The following is a description of a gene set: species: Homo sapiens Human Gene Set: CHENG_IMPRINTED_BY_ESTRADIOL Genes whose CpG islands became hypermethylated in breast progenitor cells pre-exposed to estradiol. from publication Cheng AS, Culhane AC, Chan MW, Venkataramu CR, Ehrich M, Nasir A, Rodriguez BA, Liu J, Yan PS, Quackenbush J, Nephew KP, Yeatman TJ, Huang TH (PMID 18339859) Estrogen imprinting is used to describe a phenomenon in which early developmental exposure to endocrine disruptors increases breast cancer risk later in adult life. We propose that long-lived, self-regenerating stem and progenitor cells are more susceptible to the exposure injury than terminally differentiated epithelial cells in the breast duct. Mammospheres, containing enriched breast progenitors, were used as an exposure system to simulate this imprinting phenomenon in vitro. Using MeDIP-chip, a methylation microarray screening method, we found that 0.5% (120 loci) of human CpG islands were hypermethylated in epithelial cells derived from estrogen-exposed progenitors compared with the non-estrogen-exposed control cells. This epigenetic event may lead to progressive silencing of tumor suppressor genes, including RUNX3, in these epithelial cells, which also occurred in primary breast tumors. Furthermore, normal tissue in close proximity to the tumor site also displayed RUNX3 hypermethylation, suggesting that this aberrant event occurs in early breast carcinogenesis. The high prevalence of estrogen-induced epigenetic changes in primary tumors and the surrounding histologically normal tissues provides the first empirical link between estrogen injury of breast stem/progenitor cells and carcinogenesis. This finding also offers a mechanistic explanation as to why a tumor suppressor gene, such as RUNX3, can be heritably silenced by epigenetic mechanisms in breast cancer., and this is the list of marker genes: CSTF1, SLC25A19, CLASP1, TTBK2, A1BG-AS1, TP53RK, TOR4A, LRRC45, LAMA5, MEX3B, TRIM42, FZD8, ERBIN, KARS1, GOLT1B, A1BG, BMP7, DGKG (diacylglycerol kinase gamma), ZNF496, NDUFA4L2, LCMT1, TMEM102, FEM1A, TBXA2R, MTCL3, LRRTM1, RECQL, TERF2IP, DDX56, RAC3, PRX, LRR1, TMCO1, OS9, CLK3, PAPSS2, HYCC1, RALBP1, POLR2F, CTNNA2, ZNF687, PRDM12, CERS1, TFAP2C, CLUH, SOSTDC1, VPS13B, IL17RB (NCBI Gene Id 55540), DDX50, FZD1, F7, WDR1, HOXA1, RBSN, RB1, OTX1, RPRM, ZNF384, LPAR5, IRAK2, GPR50, MAD1L1, GLB1, MRPS2, ZNF467 (zinc finger protein 467), ZNF420, PDZD4, EGR2, WNT5A, PDE9A, LDB3, BRD1, MAP2K2, LPIN1, FANCF, RUNX3, ESRP2, HNRNPL, SPTBN1, MXI1, ARPP21 (cAMP regulated phosphoprotein 21), CEP44, SCD5, TDG, SPINDOC, YBX1, KIAA0408, AURKA, ZBED4, GDF1, HS6ST2, TBX5, EMSY, FBXL18, PITX1, METTL3, ZFP36L1, RNF150, GSC, DLL4, LHX6, PTPRG, FBXO8, TMPPE, C22orf23, CHDH, UBAC2, THRB, PIM2, DUSP5P1